The following is a description of a gene set: species: Mus musculus The appearance of interferon-beta due to biosynthesis or secretion following a cellular stimulus, resulting in an increase in its intracellular or extracellular levels. Mouse Gene Set: GOBP_INTERFERON_BETA_PRODUCTION, and this is the list of marker genes: Flot1, Ddx3x, Hmgb1, Ticam1, Atg9a, Cactin, Tlr8, Pycard, Traf3ip1, Polr3a, Nmi, Ticam2 (NCBI Gene Id 225471), Ifih1, Tlr2, Trim38, Oas2, Isg15, Nlrc3, Tomm70a, Irf3, Mavs, Arrdc4, Dhx9, Tlr7 (toll-like receptor 7), Tlr3, Yy1, Oas1e, Irf7, Oas1c, Tlr9, Tbk1, Oas3, Rnf135, Oas1g, Ppm1b, Ifnar1, Morc3, Traip, Trim65 (NCBI Gene Id 338364), Polr3g, Oas1d, Irf1 (interferon regulatory factor 1), Tlr4, Polr3f, Traf3ip3, Zc3hav1, Polr3b, Ptprs, Tradd, Trim56, Oas1a, Riok3, Zbtb20 (NCBI Gene Id 80492), Rel, Tirap, D1Pas1, Traf3, Oas1f, Nlrx1, Oas1b, Ptpn11, Relb, Polr3d, Polr3c, Rigi, Oas1h, Sting1, Ptpn22, Rnf216, Crebbp (NCBI Gene Id 547230), Hmgb2, Sirpa, Hsp90aa1